Given this list of marker genes SDHC, BLVRB, PCCB, EHHADH (NCBI Gene Id 1962), DHODH, ALDH3A2, ACADSB, ACSL1, ALDH9A1, ACADVL, ACSM5, ABAT (4-aminobutyrate aminotransferase), ALDH1B1 (aldehyde dehydrogenase 1 family member B1), PCCA, IVD, ALDH1A1, ACADM, SUCLG1, ACOX1, ACADS, ALDH2, DECR1, ALDH6A1, ECHS1 (enoyl-CoA hydratase, short chain 1), DPYD, ACADL, SRD5A2, ACOX2, MMUT, here is a description of the gene set: Human Gene Set: MODULE_184 Genes in the cancer module 184. species: Homo sapiens